Given this list of marker genes SLC36A1, SLC7A1, SLC7A2, NF1, CTNS, SLC6A20, RAB3GAP1, KCNJ8, SLC38A9, PER2, ARL6IP1, SLC11A1, SLC1A1, SLC1A3, SEPTIN2, SERINC5, SLC25A26, GNAT2, SLC38A5, CLN8 (CLN8 transmembrane ER and ERGIC protein), SLC7A8, ITGB1, SLC66A1, LLGL2, ACE2, SLC17A8, SLC7A5P2, SLC25A15, SLC22A2, SLC43A2, SLC16A10, SLC25A18, SLC3A2, SLC17A6, EPM2A, SLC47A1, SLC1A5 (solute carrier family 1 member 5), KMO, SLC7A6, SLC38A6, ARL6IP5, SLC1A7, KCNJ10, GRM1, SLC38A10, PRAF2, STXBP1, SFXN1, SLC36A2, SLC38A4, SLC7A5P1, SLC1A6, SLC6A15, UCP2, DTNBP1, TTYH3, ABCC8 (NCBI Gene Id 6833), SLC7A9, SLC1A2, SLC7A10, SLC7A13, TNF, SLC38A11, SLC36A3, SLC25A22, SLC25A2, SLC25A13, SLC38A3, NTSR1, SLC25A12, SFXN3, CLTRN, PSEN1, SLC7A11, SLC38A8, SLC43A1, SLC7A3, SLC7A7, SLC6A17, SLC17A7, SLC1A4, SLC66A1LP, ATP1A2 (ATPase Na+/K+ transporting subunit alpha 2), SLC15A4, SLC7A5, VPS54, SLC36A4, SLC3A1, CLN3, SLC38A2, TTYH1, TTYH2, SLC25A29, SLC38A1, SERINC3, here is a description of the gene set: Human Gene Set: GOBP_L_AMINO_ACID_TRANSPORT The directed movement of L-enantiomer amino acids into, out of or within a cell, or between cells, by means of some agent such as a transporter or pore. studied in species Homo sapiens